Given this list of marker genes Pomc, Tspo, Crhr1, Nrg1, Crh, Ecrg4, Tac1, here is a description of the gene set: Any process that modulates the frequency, rate or extent of corticosterone secretion. Mouse Gene Set: GOBP_REGULATION_OF_CORTICOSTERONE_SECRETION species: Mus musculus